Given this list of marker genes Klf6, Cdk2ap2, Dusp1, Rgs2, Ifi27, Junb, Uba52, Hspa1a, here is a description of the gene set: Genes negatively differentially expressed in cell type: Treg upon treatment with cytokine: IFN-κ in mouse lymph nodes in vivo. Mouse Gene Set: CUI_TREG_IFNK_RESPONSE_DN Cytokines mediate cell-cell communication in the immune system and represent important therapeutic targets. A myriad of studies have highlighted their central role in immune function, yet we lack a global view of the cellular responses of each immune cell type to each cytokine. To address this gap, the authors created the Immune Dictionary, a compendium of single-cell transcriptomic profiles of more than 17 immune cell types in response to each of 86 cytokines (>1,400 cytokine-cell type combinations) in mouse lymph nodes in vivo. A cytokine-centric view of the dictionary revealed that most cytokines induce highly cell-type-specific responses. For example, the inflammatory cytokine interleukin-1β induces distinct gene programmes in almost every cell type. A cell-type-centric view of the dictionary identified more than 66 cytokine-driven cellular polarization states across immune cell types, including previously uncharacterized states such as an interleukin-18-induced polyfunctional natural killer cell state. species: Mus musculus from publication Cui A, Huang T, Li S, Ma A, Pérez JL, Sander C, Keskin DB, Wu CJ, Fraenkel E, Hacohen N (PMID 38057668)